Given this list of marker genes UMPS, CMPK1, AK5, DCK, DHODH, CDA, CTPS1, NME3, NME6, NME2P1, NME7, NME1, UCK1, UCKL1, NME9, UPP2, UPP1, NME2, AK9 (adenylate kinase 9), CAD, NME4, UCK2, UPRT, CTPS2, NME5, here is a description of the gene set: Human Gene Set: GOBP_PYRIMIDINE_RIBONUCLEOTIDE_BIOSYNTHETIC_PROCESS The chemical reactions and pathways resulting in the formation of a pyrimidine ribonucleotide, a compound consisting of nucleoside (a pyrimidine base linked to a ribose sugar) esterified with a phosphate group at either the 3' or 5'-hydroxyl group of the sugar. studied in species Homo sapiens